The following is a description of a gene set: studied in species Homo sapiens Reactome Pathway: SLBP Dependent Processing of Replication-Dependent Histone Pre-mRNAs part of: Processing of Capped Intronless Pre-mRNA There are two well-documented trans-acting factors required for histone pre-mRNA processing. These are:<p>1 Stem-loop binding protein (SLBP), also termed hairpin binding protein (HBP). This 32 kDa protein is likely the first protein that binds to the histone pre-mRNA as it is being transcribed. <p>The U7 snRNP. This particle contains the U7 snRNA, the smallest of the snRNAs which varies from 57-70 nts long depending on the species. The 5' end of U7 snRNA binds to a sequence 3' of the stemloop, termed the histone downstream element (HDE). There are a number of proteins found in the U7 snRNP. There are 7 Sm proteins, as are present in the spliceosomal snRNP. Five of these proteins are the same as ones found in the spliceosomal snRNPs and there are 2, Lsm10 and Lsm11 that are unique to U7 snRNP.<p> A third protein joins the U7 snRNP, ZFP100, a large zinc finger protein. ZFP100 interacts with SLBP bound to the histone pre-mRNA and with Lsm11 and likely plays a critical role in recruiting U7 snRNP to the histone pre-mRNA.<p> It should be noted that there must be other trans-acting factors, including the factor that catalyzes the cleavage reaction. The cleavage occurs in the presence of EDTA as does the cleavage reaction in polyadenylation, it is likely that this reaction is catalyzed by a protein. There may well be additional proteins associated with U7 snRNP, and since under some conditions in vitro processing occurs in the absence of SLBP, it is possible that all of the other factors required for processing are associated with the active form of U7 snRNP., and this is the list of marker genes: LSM11, SNRPB, SNRPE, SNRPF, SLBP, NCBP2, NCBP1 (NCBI Gene Id 4686), LSM10, ZNF473, SNRPG, SNRPD3